Given this list of marker genes APLP2, COL5A1, COL11A1, HRG, FBLN7, SPOCK3, COL13A1, EVA1C, PAFAH1B1, ADA2, SLIT3, THBS2, CXCL6, LPL, ANOS1, NRP2, CRISPLD2, REG3G (NCBI Gene Id 130120), RPL22, RTN4RL1, CCN3, POSTN, CEMIP, BMP4, FN1, FGFR1, HAPLN3, SUSD5, PTCH1, BMP7, FGFRL1, COL23A1, FGF2, LYSMD3, CCL23, NRP1, DEFB106A (defensin beta 106A), NRTN, DPYSL3, ELSPBP1, CCN1, F11, SOST, FSTL1, LIPI, PGLYRP4, USP17L24, RTN4R, APOA5, COMP, AOC1, LIPH, CHODL (NCBI Gene Id 84535), ADAMTS3, ACAN, HDGF, LIPC, SLIT1, GREM2, ITIH2, NCAN, THBS3, PGLYRP3 (NCBI Gene Id 114771), SFRP1, F2, TGFBR3L, APLP1, FGF12, RSPO1, MDK, THBS1, THBS4, TNFRSF11B, PGLYRP1, ADAMTS8, SERPINA5 (serpin family A member 5), COL5A3, APOH, FGFBP1, EFEMP2, CTSG, PRG2, APP, SLIT2, NOD1, COL28A1 (collagen type XXVIII alpha 1 chain), SELP, PRELP, SERPINC1, FBN1, SERPINE2, HYAL2, ADGRE2, H1-1 (H1.1 linker histone, cluster member), PGLYRP2, LYVE1, SULF2, PTPRF, RPL29, FGF4, ELANE, ALK, NAV2, VIT, COL25A1, SERPINA10 (serpin family A member 10), TNXB, FURIN, STAB2, CCN5, GFRA2, RSPO3, GNS, LTBP2, EGFLAM, EPYC, TGFBR3, LAYN, ANGPTL3, FGFR4, PF4, LGR6, PDCD5, VTN (vitronectin), ADAMTS1, MPIG6B, FGF10, PRSS57, GPNMB, STAB1, CFH, TGFBR2, ENG, EXTL2, CCL15, CEL, AGRN, PRNP, ITIH1, BGN, NELL1, KNG1, CXCL11, PTPRC, BSPH1, FGF14, LTF, AMBP (NCBI Gene Id 259), REG1A, CD44, SMOC1, LXN, LAMC2, NELL2, LTBP4, CCN6, CCN4, FGF7, ZNF207, PTPRS, HAPLN4, LIPG, RNASE7, SELL, HBEGF, SHH, CXCL13, MPO, HABP2, AAMP, ANG, SOD3, VEGFA, NDNF, VCAN, ADAMTS5, DEFB106B, HAPLN1, REG3A (regenerating family member 3 alpha), HK1, ZG16, FGFR2, MSTN, SMOC2, COLQ, HMMR, CCDC80, IGHM, PCOLCE, ADGRG1, ECM2, LRPAP1, SERPIND1, SEMA5A, CCL7, NOD2, ADAMTS15, PLA2G2D, PGF, SAA1, AZU1, APOE, BCAN, CCL8, HAPLN2, IMPG1, PF4V1, APOB, LPA, TENM1 (NCBI Gene Id 10405), DMBT1, TMEM184A, CCN2, FGFBP3, IMPG2, NLRP3, ADAMTSL5, SULF1, C1QBP, CXCL8 (C-X-C motif chemokine ligand 8), FGF9 (fibroblast growth factor 9), PPIA, RSPO2, REG1B, PTN, PCOLCE2, SPOCK2, REG4, CXCL10, USP17L6P, VEGFB, PODXL2, ZNF146, TLR2, DCN, CLEC3B, TREM2, FGF1, HSD17B12, JCHAIN, TNFAIP6, PCSK6, TWSG1, RSPO4, here is a description of the gene set: Human Gene Set: GOMF_GLYCOSAMINOGLYCAN_BINDING studied in species Homo sapiens Binding to a glycan (polysaccharide) containing a substantial proportion of aminomonosaccharide residues.